The following is a description of a gene set: part of: Complement cascade studied in species Homo sapiens Reactome Pathway: Activation of C3 and C5 The 3 pathways of complement activation converge on the cleavage of C3 by C3 convertases. C3 convertase cleaves C3 into C3a and C3b - a central step of complement activation. C3a remains in the fluid phase and acts as an anaphylatoxin, whereas C3b can form additional C3 convertases hastening the production of C3b. Besides, C3b binds to C3 convertases to form C5 convertase, which can act as an opsonin, or is degraded into fragments which cannot form an active convertase., and this is the list of marker genes: C3, C5, C4B, CFP, C4A, CFB, C2